Given this list of marker genes COL27A1, GSTM2, NR4A1AS, KRT17, COL16A1, TPM4, MT-CYB, ZC3H12A, EMX2, SLC7A11 (NCBI Gene Id 23657), RAMP2-AS1, ZC3HAV1, IFNGR2, KRT16, STAT6, TTC19, H2BC21, POLR2A, ZNF10, PLEKHG2, ELN, CEP95, THOC2, SFXN1, IBTK, BSDC1, NDNF, HSPA1A, BAZ2B, MYOC, PTPRE, RSPO4, ALPK1, COL1A2, ZNF37A, SHC1, SSH1, MT-ND4, COL3A1, PTPRG, HPS4 (HPS4 biogenesis of lysosomal organelles complex 3 subunit 2), VIM-AS1, DIO2, HGF, HOOK2, ZNF302, RICTOR, BTAF1, DENND2B, COX6B2, SCN2A, ETNK1, CH25H, GBP1, CP, AASS, ETV3, ARID3A, ZKSCAN1, ADAM12, MKNK2, ZFHX4, SLC25A25, NABP1, SBNO2, FBLIM1, TMEM67, CYP4X1, HIC1, MT-ND2, MT-ATP6, UGDH (UDP-glucose 6-dehydrogenase), CSF3, CRISPLD2, RHOBTB3, FAM20A, ADAM33, FGF7, CSAD, TANC2, CHST15, BHLHE40, TIPARP, HELZ2, GPRASP1, ADM, MAP1LC3A, AFF1, ITSN1, COL5A1, PRKCA, JUN (Jun proto-oncogene, AP-1 transcription factor subunit), ASXL1, OAT, UAP1, FSTL3, FNDC3A, ADAMTS9-AS2, MAPK10, ARHGAP29, DUSP1, HSPA1B, MT-ND6, NFATC1, CLIP4, MMP2, FLT1, NAV1, MCTP2, ACADVL, DUSP5, NIPBL (NCBI Gene Id 25836), PNRC1, here is a description of the gene set: Occular cell types curated from Gautam and Hamashima et al. Multi-species single-cell transcriptomic analysis of ocular compartment regulons from publication Gautam P, Hamashima K, Chen Y, Zeng Y, Makovoz B, Parikh BH, Lee HY, Lau KA, Su X, Wong RCB, Chan WK, Li H, Blenkinsop TA, Loh YH (PMID 34584087) studied in species Homo sapiens Human Gene Set: GAUTAM_EYE_IRIS_CILIARY_BODY_MEG3_HIGH_FIBROBLASTS